The following is a description of a gene set: Glycosylphosphatidyl inositol anchor pathway Human Gene Set: WP_GLYCOSYLPHOSPHATIDYL_INOSITOL_ANCHOR_PATHWAY studied in species Homo sapiens, and this is the list of marker genes: PIGU, PIGV, PIGW, PIGO (NCBI Gene Id 84720), PIGK, PGAP3, PIGG, PIGN, PGAP2, PIGA, GPAA1, PIGH, DPM2, PIGT, PIGP, PIGM, PIGY (NCBI Gene Id 84992), PIGX, PIGL, PIGB, PIGF, PGAP1, PIGQ, MPPE1, PIGC, PIGS